Given this list of marker genes TFF2, MUC6, SERPINA3, NEUROD1, TFF1, TLR9, RBP4, CRACD, TLR4, HTR4, NR1I2, IL17A, INAVA, SOX9, MUC2, SLC22A5, TFF3, ZNF830, STRAP, MUC13, VSIG1, PBLD, MUC4, NOD2, IL10RA, here is a description of the gene set: Protection of epithelial surfaces of the gastrointestinal tract from proteolytic and caustic digestive agents. species: Homo sapiens Human Gene Set: GOBP_MAINTENANCE_OF_GASTROINTESTINAL_EPITHELIUM